The following is a description of a gene set: species: Homo sapiens Human Gene Set: GOBP_ADAPTIVE_IMMUNE_RESPONSE_BASED_ON_SOMATIC_RECOMBINATION_OF_IMMUNE_RECEPTORS_BUILT_FROM_IMMUNOGLOBULIN_SUPERFAMILY_DOMAINS An immune response mediated by lymphocytes expressing specific receptors for antigen produced through a somatic diversification process that includes somatic recombination of germline gene segments encoding immunoglobulin superfamily domains. Recombined receptors for antigen encoded by immunoglobulin superfamily domains include T cell receptors and immunoglobulins (antibodies) produced by B cells. The first encounter with antigen elicits a primary immune response that is slow and not of great magnitude. T and B cells selected by antigen become activated and undergo clonal expansion. A fraction of antigen-reactive T and B cells become memory cells, whereas others differentiate into effector cells. The memory cells generated during the primary response enable a much faster and stronger secondary immune response upon subsequent exposures to the same antigen (immunological memory). An example of this is the adaptive immune response found in Mus musculus., and this is the list of marker genes: EPHB2, ZBTB1, PVR, IGHG4, BTN3A3, ARG1, IGHV1-69-2, PRKCQ, CD55, ULBP3, MLH1, CD74, IL13RA2, TMEM98, CD19, EMP2, C1QA, IRF7, RORC, NFKBID, MAP3K7, FADD (Fas associated via death domain), IGHE, IL27 (interleukin 27), MSH2, IGLC1 (immunoglobulin lambda constant 1), KMT5C, DENND1B, KLHL22, TNF, IGHV2-70, IL1RL1, TRAF3IP2, IFNB1, KMT5B, STAT3, SMAD7, TNFRSF1B, CTSH, IGHV3-20, AGER, RC3H2, RIF1, IL12A, HRAS, C6, FUT7, ENTPD7, PDCD1, RIPK2, UNG, C5, CR1, C1QB, MBL2, CEACAM1, NOTCH1, TLR8, LGALS1, IGLC3 (NCBI Gene Id 3539), HLA-F, CD1D, IL23R, JAG1, C1S, CD1B, TNFSF13B, CD28, LTA, IL23A, IGLL5, IGHV1-45, IGHV4-61, IGHV6-1 (NCBI Gene Id 28385), HLA-G, IGHG1, CD80, BATF, IGHV5-10-1, IGLC2, MASP2, LGALS9, RNF8, TREM2, IGLC6, IL18, RC3H1, OPA1, IGHV3-53, IGHD, INPP5D, PPP3CB, IGHV3-23, C4A, PRKAA1, GZMM, CLEC4G, IL4I1, LY9, PRF1, RIPK3, MYO1G, IGHV3-16, JAK3, B2M, UFL1, HLA-DRB3, CCR2, BACH2, IGHV3-15, IGHV5-51, PRKCZ (NCBI Gene Id 5590), IGHV3-33, TYK2, IGHV3-48 (immunoglobulin heavy variable 3-48), CLU, C8B, TREX1, RAET1E, SEMA4A, IGHV3-43, FCER2, CD70, FCRLB, IFNA2, JAK1, AHR, SLC22A13, IGHV1-3, STAT5A, CFI, IRF4, MYD88, IGHV1-58, TNFSF4, IGHV4-28, FBXO38, IGHV3-66, CYRIB, IGHV4-39, C4BPA, CD274, MALT1, BCL3, TRAF6, CD46, IGLL1, FZD5, NBN, MSH6, RFTN1, IGHV3-72, IGHA1, ARID5A, FOXJ1, EXO1, TRAF2, FCGR2B, IL17RA, CD81, ZBTB7B, HSPD1, SWAP70, PTPRC, CXCL13, HMGB1, AIRE, IGHV3-35, WAS, HFE, HAVCR2, C1R, HLA-DRB1, HLA-DRA, CRTAM, IGHV3-38, IGHV2-70D, PMS2, CLCF1, PSG9, IL2RB, ULBP1 (UL16 binding protein 1), DUSP22, JAK2, SOCS5, IL6R, IL33, ZP3 (NCBI Gene Id 7785), SLC15A4, RAET1G, AICDA, KLHL6, FCMR, CLC, CSF2RB, GNL1, BTK, IGHA2, CLEC6A, IGHV2-5, MR1, PRKCD, SPN, CD1E, HPX, ADAM17, SLAMF1, PTPN6, IL9, C7, IGHV4-34, ICAM1, NCKAP1L, IGHV3-21, CD1C, STX7, IL1B, IGHV1-24, SECTM1, IL1R1 (interleukin 1 receptor type 1), C4BPB (complement component 4 binding protein beta), YWHAG, ADA, XCL1, C3, IL4R, SASH3 (SAM and SH3 domain containing 3), LIG4, GATA3, SHLD1, C9, IGHV3-64 (immunoglobulin heavy variable 3-64), C8G, FCGR3A, CD7, RELB (NCBI Gene Id 5971), TNFAIP3, IGHV1-69D, IGHV2-26, CD4, SOCS3, CRACR2A, CARD9, IL18BP, GFUS, IL10, ZC3H12A, LILRB4, UNC13D (unc-13 homolog D), NDFIP1, C2, CTSC, NLRP3, IGLC7, IGHV4-31, BCL6, IGHV4-59, SUSD4, IGHG2, TBX21, CCL19, IGHV3-73, IL12RB1, FCGR2A, IL12B, ANXA1, IL27RA, FCGR3B, IGHV3-49, ERCC1, RAB27A, HLA-B, IL6ST, C1QBP, FCER1G, IL4, EXOSC6, EXOSC3, PLA2G4A, PHB1, HLA-E, ULBP2, IL18R1, SLA2, CD27, MICA, C8A, HLA-A, MEF2C, ASCL2, STAT4, USP5, IGHV8-51-1, TP53BP1, MAD2L2, IGHV1-18, C17orf99, RNF168, EBI3, FCGR1A, CLEC7A, SERPING1, LEF1, BCL10, TCIRG1, IGHV1-69, SLC11A1, TNFSF18, CD1A, FOXP3, CD8A, C1QC, CD69, AZGP1, IGHV3-74, HLA-H, EP300, ATAD5, SHLD3, TRPM4, PAXIP1 (PAX interacting protein 1), IGHV3-13, RORA, NLRP10, HMCES, MAPK3, LILRB1, IL20RB, BRD2, RSAD2, TGFB1, KDM5D, KLRC1, IGHV3-64D, TLR4, MIR21, NSD2, SCART1, HLA-C (major histocompatibility complex, class I, C), APLF, IGHV3-7, IGHV3-30, IGKC, C4B, LOXL3, NECTIN2, NFKB2, HPRT1, IGHV7-4-1, TAP2, TNFSF13 (TNF superfamily member 13), P2RX7, SANBR, IGHG3, CR1L, IL9R, IGHV7-81, SUPT6H, UNC93B1, STAT6, IGHV4-4, CD40LG, FCER1A (Fc epsilon receptor Ia), PCYT1A, C1RL (complement C1r subcomponent like), BRD4, FCGR1BP, CD40, BTN3A2, IL2, CCR6, PARP3, IL6, CR2, SHLD2, JUNB, NFKBIZ, CD226, IL7R, MTOR, RAET1L, CADM1, EBAG9, FCGR2C, HLX, IGHV3-11, SLAMF6, KLRD1 (NCBI Gene Id 92677), PKN1, TFRC